The following is a description of a gene set: Large fleshy ears species: Homo sapiens Human Gene Set: HP_LARGE_FLESHY_EARS, and this is the list of marker genes: KCNH1 (NCBI Gene Id 8656), COLEC11, ALG9, TAPT1, COLEC10, NARS1, TBL1XR1, MASP1, KCNN3, TRAPPC9, PIGN, ATP6V1B2, TNPO2